The following is a description of a gene set: Any process that activates or increases the frequency, rate or extent of fatty acid oxidation. Mouse Gene Set: GOBP_POSITIVE_REGULATION_OF_FATTY_ACID_OXIDATION studied in species Mus musculus, and this is the list of marker genes: Irs1, Abcd2, Klhl25, Akt2, Fabp1, Pparg, Mlycd, Obp2a (odorant binding protein 2A), Irs2, Nucb2, Acsl5, Ppargc1a, Ppara (NCBI Gene Id 399624), Cpt1a, C1qtnf2, Abcd1, Dgat1, Ppard, Mtln, Twist1, Gdf15, Plin5